Given this list of marker genes WT1, TIFAB, NEUROG1, CRIPTO, WNT5A, BASP1, FRS2, TDRKH, TDRD5, TASOR, NCKAP1, HOXD8 (homeobox D8), TDRD7, TBX3, PCSK6, TDRD6, FZD5, DCANP1, TBXT, PLD6, TDRD1, here is a description of the gene set: Human Gene Set: GOBP_TRIPARTITE_REGIONAL_SUBDIVISION Subdivision of the embryo along the anterior/posterior axis into anterior, posterior and terminal regions. species: Homo sapiens